The following is a description of a gene set: studied in species Homo sapiens Human Gene Set: GSE5589_LPS_AND_IL10_VS_LPS_AND_IL6_STIM_MACROPHAGE_45MIN_DN IL-10 or IL-6 stimulation of control 129xC57BL/6 murine bone marrow derived macrophages in the presence of LPS. We used microarrays to detail the global programme of gene expression changes in response to IL-6 or IL-10 stimulation in the presence of lipopolysaccharide. BMDMs were isolated from control, IL-6-/-, and IL-10-/- mice on a 129XBL/6 mixed background mice and differentiated in the presence of CSF-1 for 6-7 days. Cells were scraped and plated in 6 well plates at 2x10e6/well. Cells were washed with complete DMEM and rested for 1-2 hr before stimulation with combinations of IL-10 (10 ng/ml), IL-6 (2 ng/ml) or LPS (100 ng/ml) for 45 min or 180 mins. Complete biological replicates were performed. Genes down-regulated in bone marrow-derived macrophages (45 min): IL10 and LPS versus IL6 and LPS. from publication El Kasmi KC, Holst J, Coffre M, Mielke L, de Pauw A, Lhocine N, Smith AM, Rutschman R, Kaushal D, Shen Y, Suda T, Donnelly RP, Myers MG Jr, Alexander W, Vignali DA, Watowich SS, Ernst M, Hilton DJ, Murray PJ (PMID 17114459), and this is the list of marker genes: COX7A2, CNTD1, PLAAT3, RNASE6, PRKX, FLRT2, MAK16, DOCK10, PDIA4 (protein disulfide isomerase family A member 4), TMEM128, NEDD9 (neural precursor cell expressed, developmentally down-regulated 9), CCNB2, FUS, CHST11, SAMHD1, MPHOSPH9, GPR174 (NCBI Gene Id 84636), CARNS1, PSMB4, PARPBP, NFE2, NABP1, SLA, RIOX2, SLC6A4, BRIP1, EME1, BRCA2, IL15RA, LARP1, CENPW, EDEM1, BAIAP3, RGL1, MYC, SERPINB2, RFC4 (replication factor C subunit 4), TCP1, ST6GALNAC5, CKS2, LRG1, DENND1B, LYAR, NUTF2, CMKLR1, NANS, BAZ1A, ANLN, CCR7, USP1, C11orf24, DDX60, SERPINB9, HMGN3, FAM107B, NXPE4, UBE2S, SMARCA5, EIF3G (NCBI Gene Id 9606), SEC61B, CD79B, RNF31, ATP2A3, AZI2, GPR84, MMP14, INSL6, MED8, PABPN1, BAK1, GNA14, PSMA1, AURKA, SNRPD1, IRF2BPL, PLSCR1, MOGAT2, NRGN, CSF3R, QNG1, GFOD1, ZNF608, EZH2, CKAP4, THBS1, OSBPL3, CASP1, HARS1, GYPC, MIF, FASLG, EEF1E1, MAD2L1, ALDH18A1, THOC6, BANF1, TRAFD1, CD38, UBAC2, TMPO, GPR132, DGAT2, BATF, MBNL3, RNF34, APOD, SLC7A1, PBX1, MSR1, NFIL3, NUDT3, RIOK1, LTB4R, ACP5, AHSA1, CENPQ, PSMB5, ANXA1, CENPT, SCARF1, LUC7L, EMILIN2, ARPP19, HNRNPD, ACTR2, B3GNT5, CKS1B, DOK2, CBX4, ATG3 (NCBI Gene Id 64422), KRBA1, CAPZA2, WDR75, DAP3, MAX, SERPINE2, PDCD10, CDCA4, SCD, NOL12, FAM98B, IL12RB1, MRPL42, TBC1D1, MAP4K1, CRISPLD2, JAK2, TAF12, HSPA1B, CXCR6, HSPH1, USB1, SELENOM, IKZF2, FBXO5, GCH1, UCHL5, PGS1, EEFSEC, SDC1, CALHM6, MARS1, SYTL1, SLC39A3, TGFBR3, PXYLP1, GATA1, BLM, TICRR, SNHG6, ETF1, VCL, EVL (NCBI Gene Id 51466), ZNF593 (NCBI Gene Id 51042), ARG2, FXN (frataxin), CYRIB, GEMIN8, SELENOW (selenoprotein W), DRAM1, ACTR3, MYL9, SOD2, MBD2, ABLIM1, RGCC, PKM, FAM3C, ASB2, GOT2, KBTBD11, ETV6, TSPOAP1, ATAD5, LAT, ZNF281, RNF144A, TCOF1, CDCA8, S1PR4